Given this list of marker genes CDC23, GTF2H4, WDR45, POFUT2 (NCBI Gene Id 23275), FRAT2 (FRAT regulator of WNT signaling pathway 2), RASSF3, POGLUT2, ACOT13, SKA1, NANP, SLC35A5, CLYBL, DNAJB9, AAAS, MRPL23, CCT8, SLC16A6, PTPN18, SLC50A1, CDKAL1, CCT6A, NF2, REXO2, POC5, FLNA, TFRC, CDC42SE1, MSH6 (NCBI Gene Id 2956), SPTBN1, PGP, ANP32E, XPA, VIPAS39 (NCBI Gene Id 63894), MFSD6, UPF3B, D2HGDH, RPL30, C8G, GALT, SFXN3, EMC2, NUCB1, IMPA2, SEMA6C, MIGA2 (NCBI Gene Id 84895), NCBP1, C2CD2L, EMC6, RPL12, FUOM, CD99L2, LARP7, WIPI1, POU2F2, NME2, CLNS1A, FERRY3, SLC25A4, SCAMP1, ANXA6, BCAP29, KLF10, SKI, MBP, SMC2 (NCBI Gene Id 10592), TOPBP1, ACO2, MED23, BSG, RNF141, TSGA13, CEBPZOS, MINDY1, FANCG, CDC25C, GPBP1L1, NDUFC2, SMARCAD1, MPHOSPH9, TSPAN14, CYB5R1, EARS2, XPO4, GPR146, N4BP3, DAD1, MTMR1, ATP5MC3, ARHGAP21, ROMO1, CDK5, ZNF841, HCFC1, BAZ1B, HEBP1, CHMP7, STMP1, HNRNPL, AUH, EPS15, RPRD1A, RAMP1, BTBD1, CD81, POLE3, DKKL1, VPS35, CROT, TM9SF2, MVK, CRTAP, LEPROT, PTCD3, GSTM3, PDE8A, SIDT2, BDH1, PNKD, MYCBP2, CPSF1, EIF4G1, MCM7, RNF5, FASTKD1, PIMREG, SEPTIN2, CFL1, ABCC3, ARHGDIB, FAR1, HS1BP3 (NCBI Gene Id 64342), IL6ST, PRXL2A, TRIM59, SPEG, ZNF532, ADCY2, MRPL34, TMEM79, KLHL9 (kelch like family member 9), FAM111A, DHX16, UHMK1, FANCE, MKNK2, PHPT1, HMBS, MRPL51, MDH1, ATP5PF, ITGB2, HPCAL1, NSMF, SNHG8, NDUFS2, CDK4, PDXK, FBXO8, ELMO2, KLRD1, CCR2, ASF1B, CTSA, ADK, FDPS, RETREG2, GLCCI1, RNF181, NDUFA2, HNRNPU, ERLIN1, CLEC6A, TAX1BP3, PIK3CG, SH3BGRL3, CTNS, HERC1, SAE1, CASD1, HIGD2A, SLC40A1, KAT7, RPS6KB2, FUCA2, SEC16A, MAP2K6, DGAT1, POLG, TECR, NUP58, WDR54, NDUFAF7, IL6R, ANGPTL4, HADHB, NFATC2IP, NUCKS1, HACL1, FASN, CCAR2, here is a description of the gene set: from publication Amit I, Garber M, Chevrier N, Leite AP, Donner Y, Eisenhaure T, Guttman M, Grenier JK, Li W, Zuk O, Schubert LA, Birditt B, Shay T, Goren A, Zhang X, Smith Z, Deering R, McDonald RC, Cabili M, Bernstein BE, Rinn JL, Meissner A, Root DE, Hacohen N, Regev A (PMID 19729616) Genes up-regulated in comparison of control dendritic cells (DC) at 12 h versus those stimulated with poly(I:C) (TLR3 agonist) at 12 h. Human Gene Set: GSE17721_CTRL_VS_POLYIC_12H_BMDC_UP studied in species Homo sapiens mouse primary BMDCs were stimulated with tlr ligands and gene expression changes were profiled on Affymetrix arrays